Given this list of marker genes PRIM1 (NCBI Gene Id 5557), BRWD1, CFTR, SCNN1G, CFAP300, EIF2AK4, COL4A6, NME5, NRAS, STN1, HLA-DQB1, BLNK, CFAP74, ODAD3, STAT5B, DNAAF11, DNAAF6, EPOR, DNAL1, IKZF1, IGHM, PML, DNAH5, TSC1, NOS1, STK36, FOCAD, RFC1, SCNN1A, BAP1, HYDIN, WWOX, DNAH11, ARL2BP, HLA-B, ODAD2, PRTN3, PTPN22, FAM13A, HLA-DPA1, DSP, NUMA1 (nuclear mitotic apparatus protein 1), PMP22, CCNO, TSC2, TFG, ATL3, POT1, CD79A, PRKAR1A, DNAAF4, SPAG1, STAT3, CFAP221, DNAI2, ATP11A, PANK2, CRLF1, TRAPPC11, DNAAF2, IL17RA, ZMYND10, RSPH3, CLEC7A, OFD1, DNAJB13, NPM1, ACAT1, DNAH1, DRC1, CFAP52, FARSB, MARS1, GMPPA, RPGR, CD79B, GAS8 (growth arrest specific 8), CYBB, LRRC56, DNAAF3, CTLA4, GAS2L2 (growth arrest specific 2 like 2), TCF3, IL2RG, SPTLC1, TERC, MCIDAS, STAT1, FOXJ1, DNAAF1, NKX2-1, DNASE1L3, RSPH4A, POMT1, AAAS, COPA, DNAAF5, SPI1, RARA, TBL1XR1, BMPR2, IL17F, SFTPA2, SERPINA1, CSF2RB, BTNL2, NEK10, ZBTB16, ODAD1, SLC41A1, MT-CYB, IRF4, DLEC1, RSPH1, MPZ, FIP1L1, DNAH9, TRAF3IP2, TGFBR2, BCOR (BCL6 corepressor), LPIN2, RNF6, RSPH9, SP110, ODAD4, MUC5B, SCNN1B, DPP9, FARSA, CFAP298, HLA-DPB1, HLA-DQA1, P4HA2, HLA-DRB1, COL4A5, IL17RC, TERT, NME8, AGR2, PIK3R1, SFTPC, TTC12, RELB, SFTPA1, SLC34A2, IRF2BP2, BRAF, SLC39A7, SPTLC2, ABCA3, RTEL1, CCDC39, CCDC40, NABP1, DAW1, CCDC103, IGLL1, MAP2K1, DNAI1, PARN, GBA1, ATL1, SPEF2, LRRC8A, CSF2RA, here is a description of the gene set: A sudden, audible expulsion of air from the lungs through a partially closed glottis, preceded by inhalation. studied in species Homo sapiens Cough Human Gene Set: HP_COUGH